The following is a description of a gene set: studied in species Homo sapiens Genes up-regulated in DU-145 cells (prostate cancer) in the absence but not in the presence of a dominant negative form of AKT1 upon exposure to HGF for 48 h. Human Gene Set: XU_HGF_TARGETS_INDUCED_BY_AKT1_48HR_UP The cytokine scatter factor (SF) (hepatocyte growth factor) transduces various biologic actions, including cell motility, invasion, angiogenesis and apoptosis inhibition. The latter is relevant to understanding the role of SF in promoting tumor cell survival in different contexts, for example, detachment from basement membrane, growth in metastatic sites and responses to chemo- and radiotherapy. Previously, we showed that SF protects cells against apoptosis owing to DNA damage, by a mechanism involving phosphoinositol-3-kinase/c-Akt signaling. Here, we used DNA microarray assays to identify c-Akt-regulated genes that might contribute to cell protection. DU-145 human prostate cancer cells were transfected+/-a dominant-negative mutant Akt, treated+/-SF and analysed for gene expression using Affymetrix arrays. These studies identified SF-regulated genes for which induction was c-Akt-dependent vs -independent. Selected microarray findings were confirmed by semiquantitative and quantitative reverse transcription-polymerase chain reaction. We tested the contribution of four SF-inducible/c-Akt-dependent genes (AMPD3, EPHB2, MX1 and WNT4) to protection against adriamycin (a DNA topoisomerase IIalpha inhibitor) using RNA interference. Knockdown of each gene except EPHB2 caused a small but significant reduction in the SF cell protection. The lack of effect of EPHB2 knockdown may be due to the fact that DU-145 cells contain a single-mutant EPHB2 allele. A combination of three small interfering RNAs blocked most of the protection by SF in both DU-145 and T47D cells. These findings identify novel c-Akt-regulated genes, some of which contribute to SF-mediated cytoprotection. from publication Xu J, Gao M, Fan S, Meng Q, Goldberg ID, Abounader R, Ressom H, Laterra JJ, Rosen EM (PMID 17099727), and this is the list of marker genes: ECM1, MMP10, THEMIS2, EPHB2, FOXD1, SPSB1, AMPD3, WNT4, PLAUR, LTBP2, F2RL1, TGM2, TNIP1